Given this list of marker genes HLA-F, RAET1L, HLA-H, HLA-A, AZGP1, TAP2, HLA-C, ULBP2, HLA-E, ULBP3, HLA-G, ULBP1, B2M (NCBI Gene Id 567), RAET1G, HLA-B, RAET1E, here is a description of the gene set: studied in species Homo sapiens The process in which an antigen-presenting cell expresses peptide antigen in association with an MHC class Ib protein complex on its cell surface. The peptide antigen may originate from an endogenous or exogenous protein. Class Ib here refers to non-classical class I molecules, such as those of the HLA-E family. Human Gene Set: GOBP_ANTIGEN_PROCESSING_AND_PRESENTATION_OF_PEPTIDE_ANTIGEN_VIA_MHC_CLASS_IB